Given this list of marker genes DTX4, PRELID3A, NRTN, POU6F1, BCL2, SCAMP1, BNIP1, HOXD4, CYP2E1, HTR4, SLC18A1 (NCBI Gene Id 6570), SYT5, FIG4, ZNF592, CYP11A1, ITIH4, SLC22A6, SLC46A3, HTR7, AMFR, NTPCR, FUT6, AQP7, KRT86, MAGI1, MFN1, CD3E (CD3 epsilon subunit of T-cell receptor complex), CNKSR1, PAXIP1, NOS2, NCKIPSD, MYC, IKBKE, GRIP2, GRIK5, STK17A, RASSF1, S100A5, VKORC1, CTRL, IL13, DRC3, SLC13A2, PAX7, TMPRSS6, CRHR1 (corticotropin releasing hormone receptor 1), CLOCK, ESR1, ABCB9, DPT, ABO, NXPE3, DTNA, SYNJ2, FOSL1, TNKS, SPEF1, NF1, COX6A2, OPRL1, KCNA5, KAT8, PRKACA, AFF2, AQP5, ELAVL2, EPHB2, COL19A1, MC5R, GLE1, SLC24A1, POFUT2 (protein O-fucosyltransferase 2), KANK2, ARL3, PVR, TENM4, CAMK2G, FLT1, JRK, EXTL3, ZBTB40, ADAM20, SDC3, MSX1, ZBTB22, NR2F1, SLC16A5, CD6, DNAJC16, KRT33A, TBX5, HNF1A, SLC4A3, TBXT, ZNF500, CCKAR (cholecystokinin A receptor), JAG1 (jagged canonical Notch ligand 1), CEP135, AOC4P, DOCK1, GPATCH8, WT1, TMEM11, GJB5, SLC22A24, TBX19, ADCYAP1, RXRG, MC2R, BAHD1, CMA1, PIK3CB (NCBI Gene Id 5291), SSTR5, COLQ, NPFF, DGCR5, HTR1B, CYP2D6, SLC30A3, FNTB, RPS6KB2, OSBP, PIK3C2A, MYT1 (NCBI Gene Id 4661), ZNF157, MYO9B, C1orf216, MT4, ITPR2, TUBGCP4, PLEKHB1, SLC2A1, TBC1D22A (NCBI Gene Id 25771), DKK4, TNFRSF25, KANK3, BRD1, POU6F2, SLC33A1, BMP10, ZBTB14, KLHL18, KRR1, DAPK2 (death associated protein kinase 2), SULT4A1, CASP10, GPR15, PAX9, ZKSCAN3, ATP6V0A2, SLC6A11 (solute carrier family 6 member 11), TMEM94, ENTREP1, ADCY3, TFDP2, AMMECR1, GNPAT, MAGEA9, PIGB, CPZ, SEZ6L, ABCA1 (ATP binding cassette subfamily A member 1), PIGR, LTBP4, P2RY10, MSL3, POLR2K, SCAPER, SIX3, RBBP8, IVL, SIM2, here is a description of the gene set: Neighborhood of STK17A serine/threonine kinase 17a (apoptosis-inducing) in the MORF expression compendium Human Gene Set: MORF_STK17A Neighborhood of STK17A studied in species Homo sapiens